Given this list of marker genes CCND1, VHL, SLC2A10, FAS, CCR1, TLR4, IL12A-AS1, UBAC2, KLRC4, HLA-B, IFNGR1, CALM1, STAT4, C4A, IL12A, IL10, IL23R, GPX4, ERAP1, PPA2, IRF4, MEFV, here is a description of the gene set: species: Homo sapiens Inflammation of the myocardium. Myocarditis Human Gene Set: HP_MYOCARDITIS